The following is a description of a gene set: Human Gene Set: HP_EXCESSIVE_WRINKLED_SKIN species: Homo sapiens Excessive wrinkled skin, and this is the list of marker genes: FGFR2, MRAS, TINF2, DKC1, ATP6V1E1 (NCBI Gene Id 529), TBL1XR1, FGFR3, PARN, PLOD1, H4C5, ABCC6, RAF1, COL3A1, ACD, TGM5, TWIST2, ENPP1, PYCR1, PTEN (NCBI Gene Id 8037), ATP6V0A2, RIT1, COG7, ADAMTS2, ATP6V1A (ATPase H+ transporting V1 subunit A), ZNF469, MAP2K2, CFTR, MAP2K1, ADAMTSL2, KRAS, RTEL1, C1R, PIK3R1, TERT, SMARCA2, BRAF, CSTA, LZTR1, PTPN11